Given this list of marker genes NECTIN2, FGFBP3, DNAH2, EIF1, TAGLN2, LEMD3, HMG20B, NDUFAF4, CD200, LAPTM4B, C3orf80, IFIT1, MLLT6, GLA, CCND2 (NCBI Gene Id 894), SAA1, PIK3R1, C19orf12, CSRNP1, TRIP12, CDIPT, PAPSS2, TSPO, ABTB2, MARCKS, CST7, FAM89A, EXOC3L4 (exocyst complex component 3 like 4), UBE2F, RNF115, TRPM7, GAS2 (NCBI Gene Id 2620), GADD45B, TNFRSF11A, SDHAF1, WDR82, PDCD1LG2, CISH, ARC, POGK, CREBL2, DCTN4, IFIT1B, ATP11A, GPR85, PRKAA2, CNKSR3, CACNA1S, STAT3, PCP4, SFMBT2, TMEM19, DUOX1, INSL6, EDEM1, CDC42EP3 (NCBI Gene Id 10602), ACER2, JDP2, GLIPR2, MFSD2B, ST8SIA2, SPSB1, DLX1, USP18, CDKN1A, ANXA2, HAX1, NDRG1, FAM184B, PALLD, CHD1, CNTD1, HELZ2, TMLHE, YBX3, IRF7, CDYL, HEXIM2 (NCBI Gene Id 124790), LY75, LAPTM5, AVPR2, CAPRIN1, APOD, NXF1, CNN3, C14orf28 (chromosome 14 open reading frame 28), PCGF5 (NCBI Gene Id 84333), TMEM8B, POGLUT1, CBLB, STAT5A, SOCS2, OAS2, NRIP1, RFTN1, BCL2L14, MMP13, CLIC4, WARS1, SOCS3, ST6GALNAC6, LSM14B, ARHGAP8, EXD1, PMVK, VDR, IST1, BCL2A1, UPF1, HARS1, TUBB2B, FABP5, JADE2, RBM34, PRMT2, ETV3, GBP6, GYPC, GK, IFITM2, GPAT4, MAB21L3, BIRC2, BASP1, CEP350, GRIA1, TMEM150C, GPC1, PARP12, NFKBIA, SDC1, CCL5, SYNGR2, CA13, IL2RA, ANXA11, PPARGC1B, AIDA, KDM2B, CYB5D2, GBP2, LAD1, HOOK2, HNRNPK, PITPNC1, DRAM1, CDKN2B, SLFN5, REL, MREG, SCIN, DUSP2, TRAF2, SDC4, SOD2, VAPA, GSTT1, IFT22, ARF6, SPHK1, ENPP2, OASL, RRAS2, TCF7L1, OAS1, UBE2D2, BHLHE22, CCR7, TNNT2, CXCL11, PLEKHG2, YWHAB, TTC13, PTGER4, ISG15, PCSK1, DDX6, STK4, CCDC71L, PLA2G4F, PSME2, ADPRM, FLRT3, KTN1, KDR, F11R, FOXP4, SCG2, FSCN1, IL4I1, HTRA1, MFHAS1, SEMA7A, IL1RN, TAP2, TUBA1A, ADGRG6, CD69, CXCL10, GJA1, here is a description of the gene set: Genes down-regulated in resting CD8 T cells: wildtype versus MIR155 knockout. studied in species Homo sapiens Human Gene Set: GSE44649_WT_VS_MIR155_KO_NAIVE_CD8_TCELL_DN MicroRNA-155 (miR-155) is upregulated in primary effector CD8 T cells but is expressed at low amounts in naïve cells. Anti-viral CD8 T cell responses and viral clearance were impaired in miR-155 deficient (bic-/-) mice, and this defect was intrinsic to CD8 T cells, as adoptively transferred bic-/- CD8 T cells generated greatly reduced primary and memory responses during infection. To understand the mechanism by which miR-155 regulates CD8 T cell activation, we analyzed the gene expression profiles of naive and in vitro activated wild-type and bic-/- CD8 T cells. from publication Gracias DT, Stelekati E, Hope JL, Boesteanu AC, Doering TA, Norton J, Mueller YM, Fraietta JA, Wherry EJ, Turner M, Katsikis PD (PMID 23603793)